Given this list of marker genes SLC24A2, SLC25A6, SLC2A6 (NCBI Gene Id 55587), SLC2A2, SLC39A8, SLC47A1, EMB, SLC5A7, SLC27A6, SLC2A7, SLC5A5, SLC9A4, CTNS, SLC7A10, LCN1, SLC17A7, SLC39A14, SLCO1C1, SLC9A1, SLC35D1, SLC4A3, SLC26A2, SLC4A8, SLC39A4, SLC12A5, SLC1A7, SLC38A4, SLC9A2, SLC1A2, SLC25A4, SLC25A5 (NCBI Gene Id 292), SLC2A3 (solute carrier family 2 member 3), SLC6A15, SLCO2A1, SLC2A9, ARL2BP, SLC34A1, SLC26A6 (solute carrier family 26 member 6), SLC36A1, SLC6A5, SLC41A1, SLC5A12, SLC1A6, SLC18A1, SLC43A2, SLC22A16 (solute carrier family 22 member 16), SLC8A2, SLC22A6, SLC39A5, SLC13A4, SLC4A10, SLC5A9, SLC28A1 (NCBI Gene Id 9154), SLCO4C1, SLC15A1, SLC27A4, SLC4A4, SLC9A6, SLC5A1, SLC6A9, SLC3A2, SLC7A3, SLC12A2, SLC35A2, SLC13A3, SLC9A5, SLC4A9, SLC18A2, SLC16A7, SLC1A1, SLC35A1, SLC16A10, RHAG, SLC6A3, SLC39A6 (solute carrier family 39 member 6), SLC30A8, SLC26A3, SLC7A2, SLC43A1, SLC5A8, SLC35A3, SLC11A1 (solute carrier family 11 member 1), SLC8A3, SLC25A22, SLC16A3, SLC25A10, SLC29A3, FGF21, SLC14A1, SLC10A6, SLC4A5, SLC27A1, SLC17A1, SLC36A2, SLC5A6, LCN12, SLCO1A2, SLC16A8, SLC26A1, SLC5A3, SLC6A2, SLC24A5, SLC31A1, SLC39A7, SLC32A1, SLC39A10, SLC7A5, SLC22A3, SLC17A5, SLC35B2, SLC4A7 (NCBI Gene Id 9497), SLC5A2, AVP, SLC25A11, SLC15A3, SLC9A7, SLC7A6, SLC28A2, SLC2A13, SLC24A1, SLC2A1, SLC44A5, RHCG, SLC13A1, SLC28A3, SLC35B3, SLCO2B1, SLC12A1, SLC6A6, SLC12A4, SLC7A1, SLC13A2, SLC30A3, SLC20A1, SLC26A9, SLC14A2, SLC39A3, SLC22A1, SLC30A10, SLC22A4, SLC22A8, SLC7A7, SLC22A12 (NCBI Gene Id 116085), SLC4A2, SLC34A3, SLC29A4, SLC35B4, SLC1A3, PDZD11, SLC29A1 (solute carrier family 29 member 1 (Augustine blood group)), SLC25A26, CP, SLC38A2, SLC30A1, SLC41A2, SLC12A7 (NCBI Gene Id 26129), SLC6A14, SLC22A7, SLC34A2, SLCO1B3, SLC39A1, SLC29A2, SLC26A7, SLC50A1, SLC1A4, SLC1A5, SLC24A3, SLC6A12, SLC25A29, SLC35C1, SLC5A11, SLC2A8, SLC9A8 (solute carrier family 9 member A8), SLC15A4, SLC22A18, SLC6A18, SLC6A13, SLC16A2 (solute carrier family 16 member 2), RHBG, SLC38A5, SLC9A9, SLC40A1, RUNX1, SLC30A5, SLC20A2, SLC12A6, SLC7A8, SLC6A11, SLC26A4, SLC2A11, SLC45A3, SLC30A2, SLC47A2, MFSD4B, SLC44A2, SLC8A1 (NCBI Gene Id 6546), LCN15, SLC44A3, SLC11A2, SLC6A1, SLC16A1, SLC24A4, SLC7A11, SLC3A1, SLC38A3, APOD (NCBI Gene Id 347), SLC2A4, SLC7A9, SLC13A5, SLCO1B1, SLC25A1, SLC22A11, SLC44A1, SRI, SLC22A15, ARL2, AHCYL2, SLC22A5, SLC6A7, BSG, SLC12A3, SLC6A20, SLC39A2, SLCO4A1, SLC2A10, SLC2A14, CALM1, SLC4A1, SLC22A2, SLC35D2, SLC9A3, HEPH, SLC36A4, SLC33A1, SLC8B1, SLC2A12, SLC17A6, SLC38A1 (NCBI Gene Id 81539), SLCO3A1, LCN9 (lipocalin 9), SLC26A11, SLC5A10, SLC5A4, SLC25A18, SLC6A19, SLC17A8, SLC44A4, RSC1A1 (regulator of solute carriers 1), here is a description of the gene set: SLC-mediated transmembrane transport Human Gene Set: REACTOME_SLC_MEDIATED_TRANSMEMBRANE_TRANSPORT studied in species Homo sapiens